The following is a description of a gene set: Human Gene Set: REACTOME_DISEASES_OF_HEMOSTASIS Diseases of hemostasis species: Homo sapiens, and this is the list of marker genes: TPST1, F9 (coagulation factor IX), ADAMTS13, F2, GP5, GGCX, F10, GP1BA, F11, TPST2, KLKB1, SERPING1, COL1A2, VWF, F12, COL1A1, GP1BB, F8, GP9